The following is a description of a gene set: studied in species Homo sapiens Human Gene Set: GOBP_THALAMUS_DEVELOPMENT The process in which the thalamus changes over time, from its initial formation to its mature state., and this is the list of marker genes: CNTNAP2, SMO, OLIG2, CHRNB2, SHH, GBX2, PTCHD1, TAL2, UQCRQ, SRD5A1, OGDH, FOXB1, KIAA0319 (NCBI Gene Id 9856)